Given this list of marker genes GBA1, EIF4G1, GCH1, UQCRC1, VPS13C, PDE10A, FBXO7, LRRK2, CHCHD2 (coiled-coil-helix-coiled-coil-helix domain containing 2), HTRA2, PARK7, TAF1, UCHL1 (ubiquitin C-terminal hydrolase L1), ATP13A2, MAPT, GIGYF2, POLG, RAB39B, VPS35, ATP7B, PLA2G6, PSAP (prosaposin), TH, SNCA, DNAJC13, PTPA (NCBI Gene Id 5524), TK2, here is a description of the gene set: studied in species Homo sapiens Parkinsonism with favorable response to dopaminergic medication Human Gene Set: HP_PARKINSONISM_WITH_FAVORABLE_RESPONSE_TO_DOPAMINERGIC_MEDICATION Parkinsonism is a clinical syndrome that is a feature of a number of different diseases, including Parkinson disease itself, other neurodegenerative diseases such as progressive supranuclear palsy, and as a side-effect of some neuroleptic medications. Some but not all individuals with Parkinsonism show responsiveness to dopaminergic medication defined as a substantial reduction of amelioration of the component signs of Parkinsonism (including mainly tremor, bradykinesia, rigidity, and postural instability) upon administration of dopaminergic medication.